The following is a description of a gene set: Mouse Gene Set: GOBP_CELL_SUBSTRATE_JUNCTION_DISASSEMBLY The disaggregation of a cell-substrate junction into its constituent components. studied in species Mus musculus, and this is the list of marker genes: Prickle1, Mapre2 (microtubule-associated protein, RP/EB family, member 2), Ston1, Arf6, Iqsec1, Map4k4, Pik3r1, Dusp3